Given this list of marker genes ACSM2A, ACSM6, ACSM3, ACSF2, ACSL3, ACSM2B (acyl-CoA synthetase medium chain family member 2B), ACSM5 (acyl-CoA synthetase medium chain family member 5), ACSM4, ACSS3, ACSM1, here is a description of the gene set: Human Gene Set: GOMF_MEDIUM_CHAIN_FATTY_ACID_COA_LIGASE_ACTIVITY studied in species Homo sapiens Catalysis of the reaction: a medium-chain fatty acid + ATP + CoA = a medium-chain fatty acyl-CoA + AMP + diphosphate. A medium-chain fatty acid has an aliphatic tail containing 6 to 12 carbons.